The following is a description of a gene set: Mouse Gene Set: GOBP_DENDRITIC_CELL_CHEMOTAXIS The movement of a dendritic cell in response to an external stimulus. species: Mus musculus, and this is the list of marker genes: Ccl19, Ccl21f, Slamf1, Ccl19-ps5, Ccl21e, Ccl19-ps6, Tnfsf18, Slamf9, C1qbp, Ccl21d, Ccl19-ps3 (NCBI Gene Id 65959), Ccl19-ps1, Gpr183, Ccr6, Ccl21a, Trpm4 (NCBI Gene Id 68667), Ano6, Retnlg, Gas6, Ccl19-ps4, Slamf8, Trpm2 (transient receptor potential cation channel, subfamily M, member 2), Calr, Spi1, Ccr7, Il12a, Arhgef5, Ccl21b